Given this list of marker genes BCDIN3D, RECQL5, EARS2, PIP5K1B, B3GNT8, UROD, KLHL24, PTGR3, SP110, CMSS1, CAB39L, SNAP29, ZNF667, RABAC1, SUSD1, POLR2J, MTIF3, MON2, CHSY1, TCF12, SIDT1, CAMK2D, SERINC3, MPP1, IGF2R, PFDN6, FGD6, SLC7A6OS, DNAJC9, RUVBL1, PSMA6, POP4, YPEL3, ARHGEF3, MRGPRE, LTA, CFAP96, ABITRAM, MRPL50, HADH, MTF2 (NCBI Gene Id 22823), COASY, MAN1A2, SLX4, RIMOC1, KTN1, C19orf38, SERTAD1, HADHB, MARS1, NCK1, SLC25A19, RRN3, SPTBN1, VPREB3, COG6, NAT1, TMEM26, HEATR1, PARS2, SYS1, SCML4, IL27RA, TUBA4A, DCLK2, RFK, N4BP3 (NCBI Gene Id 23138), PPP1R13B, DYNLT3, TMEM208, KIAA2013, C17orf58, CNOT10, MAP4K1, SVBP, SPICE1, RPL37A, POLR3H, PPME1, C9orf85, TAPT1, RSL24D1, RCHY1 (NCBI Gene Id 29027), HYPK, MLLT3, JAK1, ABCD4, SPIB, MRPL23, TSR1, HDAC7, NOP10, POP7, CD99L2, TXNRD3, MAT2B, CBR1, TCF3, GUCD1, GREB1, PSEN2, USHBP1, PRMT7, MED4, FBXO9, GLMP, GNL1, SELENOW, SNX33, RNF145, NADSYN1, DMAC1, MRPL47, ACY1, EZH1, SLC16A6, ZBTB4, EIF2B2, BMAL1, TRMT1, RNF144A, LNX2, ICAM2, MIF, PSMC1, TIGD2, TRIM35, AKT1S1, MARVELD2, EXO5, TOR3A, H2BC13, GNL3, NUCB2, SDHB, C12orf57, SELENOP, CARS1, NEU1, ZNF239, SZRD1, TOM1, C1orf54, RASGRP1, AACS, TLR4, TTI2, EXOG, BTD, PQBP1, CMPK2, WDR55, ENPP1, SPIN1, DAD1, AREL1, SLC25A53, KRTCAP2, CD53, IRAK3, IL4R, ATP5F1D, TMEM223, POLR3GL, NEIL1, OXCT1, MRPL49, RAB9A, EIF3I, POLR1F, SLC2A1, SLC25A15, LYRM2, LTB, TSPO, FAM117A, CCDC71, CENPQ, NOB1, TUT1, ADD1, PDCD2, HACL1, NAE1, SCAF11, KCNK5, FCHO1, ESYT1, FKBP4, METTL26, MGST2, PCID2, BIN1, PTCD3 (pentatricopeptide repeat domain 3), PHGDH, COX11, ALDOA (aldolase, fructose-bisphosphate A), ZDHHC20, INTS7, ACTR3B, here is a description of the gene set: from publication Suryani S, Fulcher DA, Santner-Nanan B, Nanan R, Wong M, Shaw PJ, Gibson J, Williams A, Tangye SG (PMID 19965666) Human Gene Set: GSE17186_NAIVE_VS_CD21HIGH_TRANSITIONAL_BCELL_CORD_BLOOD_UP Goals/objectives: to identify various gene expression in B cell subsets derived from human PBMC and cord blood studied in species Homo sapiens Genes up-regulated in B lymphocytes from cord blood: naïve versus transitional CR2 high.